The following is a description of a gene set: from publication Marigo I, Bosio E, Solito S, Mesa C, Fernandez A, Dolcetti L, Ugel S, Sonda N, Bicciato S, Falisi E, Calabrese F, Basso G, Zanovello P, Cozzi E, Mandruzzato S, Bronte V (PMID 20605485) Genes up-regulated in CD11b+ cells from BALB/c mice bearing C26GM colon carcinoma: spleen of BALB/c mice: spleen versus tumor infiltrating monocytes. Tumor growth is associated with a profound alteration of myelopoiesis, leading to recruitment of immunosuppressive cells known as myeloid-derived suppressor cells (MDSCs). Analyzing the cytokines affecting myelo-monocytic differentiation produced by various experimental tumors, we found that GM-CSF, G-CSF, and IL-6 allowed a rapid generation of MDSCs from precursors present in mouse and human bone marrow (BM). BM-MDSCs induced by GM-CSF+IL-6 possessed the highest tolerogenic activity, as revealed by the ability to impair the priming of IFN- -producing CD8+ T cells upon in vivo adoptive transfer. Moreover, adoptive transfer of syngeneic, GM-CSF+IL-6-conditioned MDSCs to diabetic mice transplanted with allogeneic pancreatic islets resulted in long term acceptance of the allograft and correction of the diabetic status. Cytokines inducing MDSCs acted on a common molecular pathway. Immunoregulatory activity of both tumor-induced and BM-derived MDSCs was entirely dependent on C/EBP transcription factor, a key component of the emergency myelopoiesis triggered by stress and inflammation. Adoptive transfer of tumor antigen-specific CD8+ T lymphocytes resulted in therapy of established tumors only in mice lacking C/EBP in myeloid compartment. These data unveil another link between inflammation and cancer and identify a novel molecular target to control tumor-induced immune suppression. We used gene expression analysis to identify those factors, secreted by tumor-infiltrating MDSC, which could drive emathopoiesis. Moreover we compare gene expression profile of tumor-induced MDSC, obtained from either the spleen and the tumor infiltrate of tumor bearing mice, and in vitro bone marrow-derived MDSC. Human Gene Set: GSE21927_SPLEEN_VS_C26GM_TUMOR_MONOCYTE_BALBC_UP studied in species Homo sapiens, and this is the list of marker genes: ZNF731P, EEF2, KLRK1, P4HA2, PECAM1, CASS4, SRSF4, BHMT2, NHLH1, NEUROG3, CELA2B, SYNE3, PRB1 (proline rich protein BstNI subfamily 1), KRT73, PSD3 (NCBI Gene Id 55358), VN1R4, H1-6, GHRH, LBX2-AS1, KDM3A, L1TD1, PPP1R3F, MEP1B (NCBI Gene Id 4225), CD82, LINC03007, ANO8, SHOX, ENPP5, CALB2, SLC12A8, CRYGD (NCBI Gene Id 50969), HNRNPA1L2, PTPN7 (NCBI Gene Id 5778), GPR174 (NCBI Gene Id 84636), SPC24, LYPLA2, LRRN1, SOX9-AS1, CLEC4GP1, CISD1, RAB31, BTD, MYOD1, MSTN, EP400P1, COQ8B, KCNQ3, MRPL37, PPM1N, PCDHGB5, PPM1H, SPATA3, RBMY2FP, PDE3A, CREB5, GLRA2, SRR, LHPP, DUSP13B, SLC25A47, NPR2, CCNO, PRSS23, SYTL5, FGF7, USP6NL-AS1, ABCC12, KLF1, MIR3142HG, MUC7, GPR34, SEMA4B, HHIP-AS1, DNAI1, RASSF2, GML, CYP2W1, DZIP1L, DNAJB12, SMIM26, USH1G, KCNE5, STAG3, GRIN2D, HULC, NTAQ1, CT55, RNF181, ZNF281, DAAM2, PURB, PCOLCE-AS1, ARL10, SDC1, ETV6, GCM2, BEND7, CSTL1, CD84, VGF, GABRG1 (gamma-aminobutyric acid type A receptor subunit gamma1), IL18BP, RASGRP3, TEX36, PAXIP1-AS2, EN1 (engrailed homeobox 1), ATP2B1-AS1, GARS1-DT, ADAMDEC1, PPIL6, PAPSS2, LYPD4, GRIN2B, IRAG1, FMR1NB, EFCC1 (EF-hand and coiled-coil domain containing 1), WDCP (NCBI Gene Id 80304), ASB12, UST, BCL2L15, GALNTL6, PODN, PGBD4, ZNF702P, SLC7A7, PROX1, GIGYF1, IL10, PRKCI, LRG1, GREM1, DAZAP1, SNORA78, TREM1, CASP10, MCM5, NKX3-2, HERC2P1, TSKU, IFI27L1, DNAJC25, XIST, CASP4, GRM2, LNP1, PLXDC1, RAMP2-AS1, MYO7B, BTG4 (BTG anti-proliferation factor 4), KANK2, PCDHGA11, BRD3OS, EEPD1, LIAT1, CLMP (CXADR like membrane protein), HNMT, STAT4, MIR34BHG, RPL9, CHSY3, ODAPH, RCC2, CEP192, FN1, PKD1L1, RAB40A (NCBI Gene Id 142684), PI3, REG1CP, GALNT18, MMRN1, CLEC14A, LINC01056, IL20RB (NCBI Gene Id 53833), SERTM1, MGARP, LINC02860, SYNE4, HS3ST5, NHERF4, CECR9, NUCKS1, CDC25C, ITGA5 (integrin subunit alpha 5), CUBN, DUOX2, TSPY1, PWP1